Given this list of marker genes Ostn (NCBI Gene Id 239790), Mir188, Hdac7, A430033K04Rik, Zhx3, Cdk6, Mir135a-1, Wnt10b, Apc, Mef2c, Wnt7b, Sox2, Scube2, Tob1, Map2k6, Pdlim7, Igfbp3, Smad6, Hdac5, Smad1 (SMAD family member 1), Dlx5, Shox2, Bmp4, Sfrp2, Hemgn, Sox11, Fgf2, Fermt2, Notch1, Mir133a-1, Ddx5, Bglap2, Ifitm1, Shh, Mir133a-2, Erfe, Nf1, Fbn2, Smad4, Npnt, Tent5a, Gabbr1 (NCBI Gene Id 54393), Hdac4, Ptger4, Fignl1, Rspo2, Trp63, Runx2, Cthrc1, Ift80, Rassf2, Rorb, Lox, Acvr1 (activin A receptor, type 1), Twsg1, Col11a2, Satb2, Gli1, Nog, Twist2, Tnf, Mir2861, Fgf23 (fibroblast growth factor 23), Dnai3, Nr1i3, Igfbp5, Mir3960, Acvr2a, Tcirg1, H3f3a, Dhh, Id1, Glis1, Jag1, Lef1, Lrp5, H3f3b (H3.3 histone B), Zfp932, Ucma, Fto, Sox9, Bmpr2, Smad5, Junb, Bmpr1b, Mir30c-1, Lrrc17, Gli3, Lrp3, Jund, Wnt3a, Mir205, Dlk1, Ahr, Bglap3, Gnas, Clec5a, Ipo7, Gsk3b, Grem1, Prkaca, Gli2, Cyp24a1, Crim1, Fhl2, Esrra (NCBI Gene Id 269047), Sh3pxd2b, Tmem119, Atf4, Twist1, Scube3, Sfrp1, Tnfaip6, Panx3, Ppp3ca, Cebpb, Adar, Id2, Ifi204, Ltf, Cebpa, Gja1, Vegfa, Igf2, Hey1 (NCBI Gene Id 99610), Fndc3b, Ptk2, Ache (acetylcholinesterase), Wnt11, Fgf9, Axin2, Clic1, Bambi, Cited1, Wwtr1, Areg, Nppc, Sox8, Sp7, Myoc, Mir217, Tgfbr3, Bmp8a, Pthlh, Smad3, Bmp6, Fbxo5, Trpm4, Noct, Cd276, Mir204, Tmt1a, Pth1r, Fzd1, Mir210, Rest, Ccl3, Nbr1, Id4, Hira, Mir23a, Mef2d, Enpp1, Hoxa2, Mir137, Ctnnb1, Yap1, Mir338, Ilk (NCBI Gene Id 16202), Bmpr1a, Mapk14, Erh, Ddr2, Fam20c, Tmem64, Riox1, Suco, Bmp7, Gpnmb, Smoc1, Gdf2, Lgr4, Actn3, Wnt4, Akt1, Nell1, Igfbp2, Map3k7, Ccn4, Mir30c-2, Asf1a, Fosl2, Epha2, Penk, Cbfb, Spp1, Mapk11, Cebpd, Bmp3, Vegfc, Prkd1, Lmna, Col1a1, Ctnnbip1, Fgfr1, Igf1, Ptch1, Ski, Il6st, Prmt3, Sema4d, Ccn1, Hand2, Hdac8, Tmt1a3, Gdf10, Tmt1a2, Mir214, Sirt7, Snai1, Ihh (Indian hedgehog), Msx2, Ranbp3l, Wnt3 (NCBI Gene Id 22415), Il6, Bmp2, Trp53inp2, Smo, Acvr2b, Men1, Gdpd2, Bglap, Atraid, Tmem53, Mir3065 (NCBI Gene Id 100526518), Limd1, Chrd, Gas5, Id3, Nfatc1, Creb3l1, Snai2, Ffar4, Wwox, Pparg, Tnn, here is a description of the gene set: Mouse Gene Set: GOBP_OSTEOBLAST_DIFFERENTIATION studied in species Mus musculus The process whereby a relatively unspecialized cell acquires the specialized features of an osteoblast, a mesodermal or neural crest cell that gives rise to bone.